The following is a description of a gene set: species: Homo sapiens Human Gene Set: GSE3982_NEUTROPHIL_VS_TH2_UP Genes up-regulated in comparison of neutrophils versus Th2 cells. from publication Jeffrey KL, Brummer T, Rolph MS, Liu SM, Callejas NA, Grumont RJ, Gillieron C, Mackay F, Grey S, Camps M, Rommel C, Gerondakis SD, Mackay CR (PMID 16474395) In the present study we used Affymetrix oligonucleotide microarrays to produce gene transcription profiles for the major leukocyte types in humans. This comprehensive dataset enabled us to not only establish which genes were expressed in each leukocyte type, but also which genes were expressed in each subset after activation. The used of a comprehensive dataset of gene profiles from all the major human leukocyte subsets enabled a novel and powerful means for identification of genes associated with single leukocyte subsets, or different immune paradigms., and this is the list of marker genes: GIT2 (NCBI Gene Id 9815), CYTH4, MYO9B, LTBP2, RARB, ARHGAP45, F2RL1, IMPDH1, GMIP, SERPINA3, ADGRE2, MMP25, RRP12, MED25, S100A11, DENND5A, OR12D2, PADI4, TRAF6, DNAJB12, NPPC, PAK2, GOLGB1, ZDHHC17, RAB33B, OGFRL1, LYZL6, RAB36, PAK1, SEC24B, MPPE1, JMJD1C, R3HDM2, RAC2, IL22RA1, CFD, TMBIM4, AKAP17A, ULBP1, IFNB1, CEMP1, GAD2, BAZ2B, MINDY1, PFKFB3, CXCL6, SH3BP5, ITIH4, XAF1, SH2D3A, NOVA2, RNF44, RNF19B, G6PC2, ARID3B, IFNAR2 (interferon alpha and beta receptor subunit 2), KDM5A, LAPTM5, FMO6P, SPTLC2, RIOK3, EXD3, AXIN1, ZZEF1 (zinc finger ZZ-type and EF-hand domain containing 1), ZNF440, PGAP6, ZNF394, KLF4, SPATA1, ZCCHC2, DUSP22, ARL4A, ACOX1, VCL, CAPZA2, EVI2B, FLOT1, DYNC1I1, PTEN, TLR6, APAF1, EGFR, H2BC5, CEBPA, PSG4 (NCBI Gene Id 91051), EVI2A, BTN2A1, SYNJ1, SLC30A3, APH1B, NBR1, UCP1, ABCC5 (ATP binding cassette subfamily C member 5), NIBAN1, CDK19, UBE2D3, HK3, RHBDL1, EFHD2, CLTCL1, IMPA2, KLHL21 (kelch like family member 21), CSK (NCBI Gene Id 1445), GNAQ, SYNE2, ATP5F1E, TREM1, OVOL2, VAV3, L1CAM, YIF1B, CDK12, ELN, WDR26, MAPK1, CACNA2D3, RASGRF1, NABP1, SERP1, HEY1, DACH1, CUL4B, SLC12A6, CDS2, NLRP1, THNSL2, UPK3A, IFIT2, NTRK3, GMPR2, NCAM1, PSME4, OTULINL (OTU deubiquitinase with linear linkage specificity like), SLC7A7 (solute carrier family 7 member 7), RIPOR1, E2F3, PARP8, LRRFIP1, STAC, BICC1, ZFP36L1, PI3, MAML1, SPAG9, IL1R1, MEOX2, HTR2A, ARSF, ACTR3, PAH, SMCP, ATP1B2, CD248, ACTA1, NTSR2, CLEC4E, TSPAN32, ABCC2, PISD, TNP1, RBCK1, ZNF516, CHSY1, DPEP2, ECM1, RALGPS1, NECAP1, RAB2A, KRTAP2-4, CEACAM4, FAM53B, MARK3, USP4, SLC22A4 (NCBI Gene Id 6583), ACTN1, SLC11A1, CCNJL, SLC22A14, POU2F1, TBL1X, MAPK8IP3, CLK1, NFYA, FBP1, SH3BGRL, DIO3, ARPC3, IDO1, MAP1S, PACSIN2, ADAM29, NCR2, FOXN3, VPS37B, REG1B, PKN2, TOR1AIP1, PSTPIP2, NCOA4, HRH3